The following is a description of a gene set: Genes predicted to be targets of miRBase v22 microRNA mmu_miR_489_3p in miRDB v6.0 with MirTarget v4 prediction scores > 80 (high confidence targets). from publication Chen Y, Wang X (PMID 31504780) Mouse Gene Set: MIR_489_3P studied in species Mus musculus, and this is the list of marker genes: Slco1a6, Foxj3, Elovl5, Rpsa, Dnajc27, Hnrnpab, Pom121l2, Tex11, Wdr59, Dek (NCBI Gene Id 67004, DEK proto-oncogene), Kbtbd2, Ei24, Pole4, Ulk1, Lats2 (NCBI Gene Id 50523), Prdm8, Cntln, Znhit6, Sema3a, Syncrip, Acsm2, Erfe (erythroferrone), Pde4d, Vav3, Eda2r, Larp4b (NCBI Gene Id 442810), Wapl, Usp45, Ptprn2, Bcor, Kctd14 (potassium channel tetramerisation domain containing 14), Clxn, Hdgfl3, Ppp4r3a, Serpinb9g, Phip, Brd10, Cyp7a1, Lhx9, Shisa7, Neto1, Smc1b, Stc2, Tmem204, Knstrn, Eaf1, Ptp4a2, Amph (amphiphysin), Golga1, Tmtc3, Ddo, Aspn, Kng1, Gpatch2l, Ap3m1, Sh3rf1, Vps13d, Kat8, Cadps2, Nemp1, Sftpa1, Lgi4, Dact1, Kctd2, Mtf2, Tnc, Spata3, Ocrl, Ajap1, Eif5